The following is a description of a gene set: studied in species Homo sapiens Human Gene Set: AGTCTAG_MIR151 Genes having at least one occurence of the motif AGTCTAG in their 3' untranslated region. The motif represents putative target (that is, seed match) of human mature miRNA hsa-miR-151 (v7.1 miRBase)., and this is the list of marker genes: RREB1, ERGIC2, RAN, DDX3X, PAPOLB, RDH10, KLF12, CAMTA1, SEPTIN11, VDAC3, NELL1, CRK, RHPN2, TWIST1, PDS5B, HPCAL4, LSMEM2, BRINP3, SULF1, RBM5, RTL9, RNF115, CACNB4, INPP5A